The following is a description of a gene set: from publication Chen Y, Wang X (PMID 31504780) studied in species Homo sapiens Human Gene Set: MIR576_3P Genes predicted to be targets of miRBase v22 microRNA hsa-miR-576-3p in miRDB v6.0 with MirTarget v4 prediction scores > 80 (high confidence targets)., and this is the list of marker genes: RIMS2, MCCC2, KDM6A, PIERCE1, ADD3, GRM5, MYBL1, TAGAP (NCBI Gene Id 94011), SLITRK1, FGF2, CLUL1, PHYH, MPHOSPH8, SPIB, GTF2A1, DOCK9, HAO1, EGR3, SMTNL2, CNOT2, NHLH2, TEX10, FGL2, MS4A1, LIN28A, MED27, NDUFAF5, DDI2, C3orf70, TMEM65, GNG5, FAM9B, STOX1, KLHL24, RAB2A, ADGRB3, C5orf24, RORA, NAALADL1, EFCAB2, GABPB1, PPP2R5E, DNAH12, EGLN1, SCNN1G, MARCHF11, GREB1, MYOT, VWA3B, PAPOLB, STAG2, SIKE1, MAPK6, ISL1, CALML4, MZT1, ENTPD5, TAB2, MED29, ZNF680, PTPRT, ARHGAP15, HOOK3